Given this list of marker genes CA13, ODF1, PFN2, IGF2R, TECPR2, FRYL, FBLN5, CCDC174, HMG20B, MACROH2A1 (NCBI Gene Id 9555), SNX27, SNRNP25, here is a description of the gene set: We previously showed that transgenic enhancement of histamine production in B16-F10 melanomas strongly supports tumor growth in C57BL/6 mice. In the present study, gene expression profiles of transgenic mouse melanomas, secreting different amounts of histamine, were compared by whole genome microarrays. Array results were validated by real-time PCR, and genes showing histamine-affected behavior were further analyzed by immunohistochemistry. Regulation of histamine-coupled genes was investigated by checking the presence and functional integrity of all four known histamine receptors in experimental melanomas and by administering histamine H1 receptor (H1R) and H2 receptor (H2R) antagonists to tumor-bearing mice. Finally, an attempt was made to integrate histamine-affected genes in known gene regulatory circuits by in silico pathway analysis. Our results show that histamine enhances melanoma growth via H1R rather than through H2R. We show that H1R activation suppresses RNA-level expression of the tumor suppressor insulin-like growth factor II receptor (IGF-IIR) and the antiangiogenic matrix protein fibulin-5 (FBLN5), decreases their intracellular protein levels, and also reduces their availability in the plasma membrane and extracellular matrix, respectively. Pathway analysis suggests that because plasma membrane-bound IGF-IIR is required to activate matrix-bound, latent transforming growth factor-beta1, a factor suggested to sustain FBLN5 expression, the data can be integrated in a known antineoplastic regulatory pathway that is suppressed by H1R. On the other hand, we show that engagement of H2R also reduces intracellular protein pools of IGF-IIR and FBLN5, but being a downstream acting posttranslational effect with minimal consequences on exported IGF-IIR and FBLN5 protein levels, H2R is rather irrelevant compared with H1R in melanoma. species: Mus musculus from publication Pos Z, Wiener Z, Pocza P, Racz M, Toth S, Darvas Z, Molnar V, Hegyesi H, Falus A (PMID 18339882) Genes gradually up-regulated by histamine in B16-F10 melanoma tumors. Human Gene Set: POS_RESPONSE_TO_HISTAMINE_UP